Given this list of marker genes Tra2b, Mdga2, Traf6, Trim25, Adam21, Pdcl3, Glis2, Sox5, Ccdc96, Ube2g1, Rdh10, Gm5796, Sf3b1, Myo15a, Garre1, Sytl5, Srsf2, Susd3, Grhl3, Pnpo, Epha5 (NCBI Gene Id 13839), Npy2r, Ddc, Amotl2, Cherp, Sertad2, Matcap2, Map3k20, Ufc1, Paxip1, Hps3, Septin6, Bach2, Pik3r1, 5031439G07Rik, Adam22, Cd164, Zfp777, Ing3, Cnot6l, Ttc7b, Enc1, Atf7, Paf1, Pten, Atp2b1, Cldn22, Colq, Eif4g2, Dtna, Zfp598, Wdr38, Usp38, Smpd1, Atrx, Isca2, Arid1b, Il9r, Akt1s1, Thap12, Inpp4a, Msi2, Caap1, Ube2e1, Rnf152, Kcnd3, Efhd2, Frk, Snrnp48, Ptrh2, Zmynd19, Cnot2, Gm10408, Inpp4b, Eef1e1, Arrdc3, Vgll3, Acbd3, Ssr3, Plb1, Akt2, Tmem230, Satb2, here is a description of the gene set: Genes predicted to be targets of miRBase v22 microRNA mmu_miR_6981_3p in miRDB v6.0 with MirTarget v4 prediction scores > 80 (high confidence targets). Mouse Gene Set: MIR_6981_3P studied in species Mus musculus from publication Chen Y, Wang X (PMID 31504780)